Given this list of marker genes SLC5A5, here is a description of the gene set: Reactome Pathway: Defective SLC5A5 causes thyroid dyshormonogenesis 1 (TDH1) part of: SLC transporter disorders Human SLC5A5 encodes the Na+/I- symporter NIS which is localised in the basolateral membrane of thyrocytes facing the bloodstream where it mediates iodide accumulation into these cells. Defects in SLC5A5 can cause hyroid dyshormonogenesis 1 (TDH1; MIM:274400), a disorder characterised by the inability of the thyroid to maintain a concentration difference of readily exchangeable iodine between the plasma and the thyroid gland (termed iodine trapping) leading to congenital hypothyroidism (Spitzweg & Morris 2010, Grasberger & Refetoff 2011). studied in species Homo sapiens